The following is a description of a gene set: Ectopia pupillae Human Gene Set: HP_ECTOPIA_PUPILLAE A malposition of the pupil owing to a developmental defect of the iris. studied in species Homo sapiens, and this is the list of marker genes: FGFRL1, COL8A2, VSX1, TBX2, OVOL2, MAB21L2, LETM1, PITX2, COL4A1, ADAMTSL4, CPLX1, ZEB1, WT1, CPAMD8, PCYT1A, ZEB2, GRHL2, NSD2, PAX6, FBN1, FOXC1, RHOA, CTBP1